The following is a description of a gene set: Human Gene Set: GOBP_CARDIAC_CHAMBER_FORMATION The developmental process pertaining to the initial formation of a cardiac chamber from unspecified parts. A cardiac chamber is an enclosed cavity within the heart. species: Homo sapiens, and this is the list of marker genes: TBX20, EDNRA, HAND2, MEF2C, TBX5, NOTCH1, TBX2, BMP2, MESP1 (NCBI Gene Id 55897), NKX2-5, SMARCD3, HAND1